The following is a description of a gene set: Human Gene Set: HP_ABNORMAL_CIRCULATING_LIPID_CONCENTRATION Abnormal circulating lipid concentration Any deviation from the normal concentration of a lipid in the blood circulation. studied in species Homo sapiens, and this is the list of marker genes: LIPA, ASL (argininosuccinate lyase), MTTP, NPHP1, ACOX2, TDP1, EIF4H, SLC2A2, CEP19, LIPC, ACADM, GTF2IRD2, AEBP1, BSCL2, YARS1, RAI1, GPIHBP1, PIK3CG, PSMB4, FOS, BBS12, ALB (NCBI Gene Id 29004), SNORD115-1, SLC22A5 (NCBI Gene Id 6584), MYT1L, GLYCTK, MC4R, LEPR, LMF1, AMACR, APOC3, TBL1X, CCDC115, PHKB, SYNE1, PLAAT3, GTF2I, NCF1, BBS1, ABCG5, UBR1, PEX14, FLII, SCARB2, XIAP, DHCR7, COL7A1, NADK2, SCP2 (NCBI Gene Id 6342), EXTL3, LMBRD1, SMARCAL1, ALG6, BCAP31 (B cell receptor associated protein 31), SGPL1, KDM1A, TFG, CPT1A, LMNB2, ACTN4, DEAF1, AGPAT2, NSDHL, SLC25A36, CLIP2, MMEL1, SLC25A20, GNAS, HR, GTF2IRD1, MCFD2, AR, LIMK1, PEX19, CREB3L3, ETHE1, TANGO2, HMGCL, BBS5, CYP7A1, ABCA1, ADRA2A, SLC19A1, EMD, STX11, TSHB, JAG1, CAV3, FHL1, STX1A, CELA2A, HNF4A, BAZ1B, PSMB10, ARMC5, LPL, CYP7B1, PIGH, NUP107, PHKG2, SLC7A7, MT-TE, MYO5A, MKS1, PEX2, PNLIP, MMAB, PPP1R17, CAVIN1, CCT5, VPS37D (VPS37D subunit of ESCRT-I), APTX, POU2AF1, BBS9, SCLT1, PCSK9, FECH, APOC2, ABCA2, ATP6AP1, PHYH, NSMCE2, AIP, TTPA (NCBI Gene Id 7274), SLC12A1, PRF1, ABCC8, TBL2, SH2B1, SLC25A13, LDLR, PEX1, COG4, CTNS, ABHD5, GLA, FBN1, DNM1L, ATAD3A, GCDH, PIGT, ACAD9, LTC4S, SCO1, EHHADH, IL12RB1, LEP, SLC34A1, NGLY1, PNKP, HTT, IFT74, PEX16, PPARG, UCP2, BBIP1, HADHA, ELN, SNORD116-1, MMACHC (NCBI Gene Id 25974), SLC37A4, PEX6, IL12A, UBE3B, MCM10, NPHS1, IRF5, LMNA, LYRM7, PSAP, PEX3, OBSCN, HADH, MEG3, RAB27A, PMM2, SYNE2, LMAN1, KCNJ1, GALK1, PSMB8, BBS10, BBS7, ACADVL, POLR3A, GYS2, FKBP6, STX5, MSMO1, RSPO1, GK, MKKS, MCCC2, PEX26, TNFRSF9, TAFAZZIN, COX16, HNF1A, GALNT2, MYO5B, CPT2, PHKA2, MMP1, GNPAT, CIDEC, LZTFL1, DNAJC30, POLD1, SLC52A1, RFC2, SAR1B, APOE, LYST, MTX2, HSD3B7, PEX11B, REPS1, PWAR1, IFT56, ZMPSTE24, PEX13, TMEM43, ABCD1, TNFSF15, BUD23, ABCG8, ANGPTL3, SLC29A3, DEF6, SCAPER, PLIN1, PNPLA2, LRP6, G6PC1, HERC2, TRMU, EBP, AGL, ARL6, PCYT1A, ALG9, PWRN1, B4GALT1, MAGEL2, DCAF17, DLK1, GBA1, METTL27, APOA5, OCRL, GPR101 (G protein-coupled receptor 101), DOLK, FARSA, SC5D, HAVCR2, DYRK1B, BBS2, HSD17B4, HMGCS2, NPAP1, IVD, SLC2A3, ATAD1, NDUFA2, CYP19A1 (cytochrome P450 family 19 subfamily A member 1), EPHX2, XRCC4, DHCR24, FLCN, CYP27A1, PLVAP, DLD, LCAT, SMPD1, APOA2, PYGL (glycogen phosphorylase L), DGAT1, ACADS, TMEM270, UNC13D, ABCB4, TMEM199, AKT2, CYP11A1, CFHR1, NPHS2, PEX5, APOA1, ADCY3, PEX12, RTL1, GATM, CETP, TBCK, FDFT1, KCNJ11, CAV1, TNPO3, PGM2L1, PEX7, CNBP, GHR, MEF2A, MKRN3, LDLRAP1, GPD1, BBS4, WRN, LIPE, WDPCP, CEP290, ALG12, STXBP2, ALMS1, PIK3R5, PLA2G7, ACAD8, CFH, PEX10, PLA2G4A, IFT172 (NCBI Gene Id 26160), TRIM32, NDUFAF6, MCEE, KIF12, APOB, IQSEC2, IFT27, SETX, ABCD4, DIO1, CFHR3, SDCCAG8, TTC8, SPIB, CFAP418, AP1S1